The following is a description of a gene set: Mouse Gene Set: GOBP_DICARBOXYLIC_ACID_CATABOLIC_PROCESS species: Mus musculus The chemical reactions and pathways resulting in the breakdown of dicarboxylic acids, any organic acid containing two carboxyl (-COOH) groups., and this is the list of marker genes: Acot4, Got2, Ddo, Glud1, Acot8, Gad1, Mthfsl, Aasdhppt, Gad2, Aldh1l1, Aldh1l2, Pm20d2, Got1, Qprt, Adhfe1, Acsf3